The following is a description of a gene set: Binding to a peptide, an organic compound comprising two or more amino acids linked by peptide bonds. studied in species Mus musculus Mouse Gene Set: GOMF_PEPTIDE_BINDING, and this is the list of marker genes: Pex19, Kdelr3, H2-Q6, Fpr3, Kdelr1, Galr2, Timm22, Trbv29, Nup153, Tomm20, Ang4, Tm2d1, Galr1, Adrb2 (NCBI Gene Id 269028), Pirb, H2-M10.1, Furin, Npy6r, Fpr-rs7, Mrgprb2, Trav7d-6, Sstr2, Nup58, H2-T23, Hsp90ab1, Vbp1 (von Hippel-Lindau binding protein 1), Clstn1, Fpr-rs6, Tap2, Apoe (NCBI Gene Id 11816), Gria2, Ang5, H2-T3, Pex7, Tmem158, Nln, H2-DMb2, Kiss1r, Tnpo2, Insr, Nmur2, Cemip, Marco, Mrgprb3, Npr3, Tpp1, B2m, H2-Aa, Srp14, Itgb2l, Tomm22, Ide, Npy5r, Pfdn1, Ctsd, Nup214, Nolc1, Itm2a, Ldlr (NCBI Gene Id 16835), Mrgprb1, Rplp0, Nlrp6, Cd36, H2-M10.6, H2-Q10, Mrgprb8 (MAS-related GPR, member B8), Hba-a1, Sstr1, Crhbp, Cltc, Ppif, Oprd1, Npepps, H2-K1, Trav14-2, 2410137M14Rik, Mrgpra3, Lrp8, Maml1, Msr1, H2-Ab1, Crhr1, Tgfb2, Mme, Itm2b, Trav7d-4, H2-M5, Oprl1, H2-T22, Trav23, Cabp1, Anpep, Pex5, Brap, Gria1, Adcyap1r1, Mc4r, Chrna7, Trav14-3, Fpr-rs4, Trav7-6, Prnp, Ephb2 (NCBI Gene Id 13844), Srp54c, Fpr-rs3, Tomm20l, H2-T24, Npbwr1, Dhcr24, Kpna3, Dlgap3, H2-Q4, H2-Ob, Ldlrad3, Cst3, Clu (clusterin), Trav7n-5, H2-Eb1, Rps6kb2, Slc7a9, Tpp2, Trav14-1, H2-M10.4, Kpna2rt, H2-Eb2, H2-M10.2 (NCBI Gene Id 333715), Sec61a2, Pfdn6, Pcsk5, Fzd4 (frizzled class receptor 4), Fpr2, Adnp, Bace1, Gpr37, Apba3, Trbv1, Apba2, Ogt, Apoa1, Prlhr, Ranbp6, Grin1, Rxra, H2-Oa, H2-M3, Calr, Pfdn4, Sctr, Clta, Dpp4, Kcnj1, Trav7-3, Trav14n-3, Trav15-2-dv6-2, H2-DMa, Srp68, Csnk1a1, Mrgprb4, Erap1, Gria3, Gss, Pom121l2, Pex13, Kdelr2 (NCBI Gene Id 66913), Cma2, Kpna6 (NCBI Gene Id 16650), Nmur1, Srp54b (signal recognition particle 54B), Memo1, Trav7-2, Tlr2, H2-Q1, Cma1, Thop1, Gprasp2, Trem2, Cryab, Gpr149, Grpr, Gpr171, H2-D1, H2-M2, Tomm70a, Kpna4, H2-T13, Apbb1, Kpna2, Npy1r, Gsap, H2-DMb1, Mcpt9, Ngfr, Cmklr2, Fntb, Atp1a3, Plod1, Tap1, H2-M10.3, Trhde, Sec61a1, Cd74, Nr1h4, Lnpep, Pom121, Hspa8, Trav7n-4, Trav14d-3-dv8, Pparg (peroxisome proliferator activated receptor gamma), Lbr, Fcgr2b, Mrgprb5, Bdkrb1, Tnpo1, Sstr4, Apbb3, Itga2, Oprm1, Ctsl (NCBI Gene Id 320361), Omp, Rps6kb1, Ctsb, Mchr1, Srp54a, Enpep, Rnpep, Cltb, Oprk1 (NCBI Gene Id 18388), Tubb3, Nfkbia, Sstr3, Fbxo2, Ang, H2-Q7, H2-M10.5, Rela, Mas1, Ang6 (angiogenin, ribonuclease A family, member 6), H2-Q2, Mrgprx2, H2-T10, Sstr5, Prep, Ipo4, Npy4r, H2-T15, Fzd5, Hmgb1, H2-M11, Tapbp (NCBI Gene Id 28066), Calcr, Fcgrt, Ipo5, Crip1, Pfdn5, Trav7-1 (T cell receptor alpha variable 7-1), Pfdn2, Trav7-5 (T cell receptor alpha variable 7-5), Ang2, Apba1, Sorl1, Hsd17b10, Kpna7, Nup98 (NCBI Gene Id 330609), H2-T5, Ager, Kpnb1, Col25a1 (NCBI Gene Id 77018), Itm2c, Scarb1, Trav7-4, H2-M1, Trav14n-2, Itgb2, Tomm40l, Fnta, Pggt1b, Ap2m1, H2-Ea, Trav14n-1, Trav19, Gpr37l1, Kpna1, Mc3r, Pex5l, Ptgdr2, H2-M9, Apbb2, Ldlrap1